The following is a description of a gene set: A highly soluble, elongated protein complex found in blood plasma and involved in clot formation. It is converted into fibrin monomer by the action of thrombin. In the mouse, fibrinogen is a hexamer, 46 nm long and 9 nm maximal diameter, containing two sets of nonidentical chains (alpha, beta, and gamma) linked together by disulfide bonds. studied in species Mus musculus Mouse Gene Set: GOCC_FIBRINOGEN_COMPLEX, and this is the list of marker genes: Serpinf2, Fn1, Fga, Fgb, Thbs1, Fgg